Given this list of marker genes Kng2, Tent4b, Ak2, Morf4l1, Mid1, Ncoa4, Uroc1, Foxo6, Slc35d2, Eif5, Setbp1, Fat3, Or52z1 (olfactory receptor family 52 subfamily Z member 1), Zfp280d, Fbxo44, Gnpda2, Fam135a, Dst, Nf1, Mzb1 (NCBI Gene Id 69816), Camk1g, Ryr2, Zfp932, Epm2aip1, Ywhaz, Neurod2, D16Ertd472e, Ccdc50 (coiled-coil domain containing 50), Gpcpd1, S1pr3, Ctnnd2, Folr2, Zkscan8, Tex55, Hdac9 (NCBI Gene Id 79221), Inpp5j, Tox, Pld1, Adamtsl1, Timm23, Gsg1l, Kng1, Mogs, Plcxd2, Slc35f1 (NCBI Gene Id 99729), Ikbkg (inhibitor of kappaB kinase gamma), Lrrc74b, Dusp23, Mtmr9, Fmr1nb, C4bp, Nbea, Inpp4b, Stox2, here is a description of the gene set: from publication Chen Y, Wang X (PMID 31504780) Genes predicted to be targets of miRBase v22 microRNA mmu_miR_1934_3p in miRDB v6.0 with MirTarget v4 prediction scores > 80 (high confidence targets). studied in species Mus musculus Mouse Gene Set: MIR_1934_3P